The following is a description of a gene set: Mouse Gene Set: GOMF_NUCLEASE_INHIBITOR_ACTIVITY Binds to and modulates the activity of a nuclease. species: Mus musculus, and this is the list of marker genes: Rnh1, Gm28729, Tmbim6, C1qbp, Dffa, Dynll1, Abce1